Given this list of marker genes Hk1, Pmm1, Pmm2, Gmppa, Gmppb, Mpi, here is a description of the gene set: studied in species Mus musculus The chemical reactions and pathways resulting in the formation of GDP-mannose, a substance composed of mannose in glycosidic linkage with guanosine diphosphate. Mouse Gene Set: GOBP_GDP_MANNOSE_BIOSYNTHETIC_PROCESS